The following is a description of a gene set: Human Gene Set: GOBP_FOREBRAIN_NEURON_DEVELOPMENT The process whose specific outcome is the progression of a neuron that resides in the forebrain, from its initial commitment to its fate, to the fully functional differentiated cell. studied in species Homo sapiens, and this is the list of marker genes: SLC4A10, NDNF, SLIT3, ROBO2, PLXNA3, DISC1, NRP2, ARX, DCLK2, OGDH, GBX2, NHLH2, FOXG1, RAPGEF2, SECISBP2, DRD2, WNT5A, LHX6, FGFR2, UBB, SLIT1, RAC1, PLXNA1, ROBO1, FEZF2, SEMA3E, ATF5, DRD1 (NCBI Gene Id 1812), ATP7A, RAC3, LHX8, CNTN2, NRP1, SOX1, ZMIZ1, FGF8, SLIT2, SCYL2, UQCRQ